Given this list of marker genes WFDC2, GREM1, POU3F3, FGF2, ID4, WT1, IRX1, WNT4, FOXC1, PAX8, PAX2, HOXB4, ITGA8, HOXA6, EYA1, HOXC11, CTNNB1, HNF4A, GDNF, GFRA1, MECOM, LHX1, LFNG, GATA3, SLIT2, ROBO2, IRX2, SIX1, WNT9B, BMP4, PCDH19, SALL1, JAG1, WNT11, NPNT, HOXA11, OSR1, ITGB1, HNF1B, EMX2, PLAC8, FOXC2, HOXD11, SIX2, RET, DLL1, here is a description of the gene set: studied in species Homo sapiens Human Gene Set: REACTOME_KIDNEY_DEVELOPMENT Kidney development